The following is a description of a gene set: species: Homo sapiens MAPK family signaling cascades Human Gene Set: REACTOME_MAPK_FAMILY_SIGNALING_CASCADES, and this is the list of marker genes: PAK3, SPTA1, PPP2CA, DUSP16, MAPK1, GFRA1, PSMB7, IL2RG, FYN, FGF9, TYK2, IL2, FGF22, PRKCQ, PSMA4, RASA2, FGF18, FGF2, PPP2R5A, RASA4, FGFR2, KIT, CCND3, PSMC3, MAPKAPK5, PEBP1, KALRN, PSMC2, RASGRP4, PRKACA, RALGDS, RASAL2, FGF10, PSMA1, CSK, FLT3, PPP2R5B, PSMB2, AGO3, FRS2, EGFR, FGFR3, MYC, FGF17 (fibroblast growth factor 17), TEK, EPGN, PDGFB, DUSP4, PSMA5, TNRC6A, PAK1, PSMB1, FGB, GRB2, CDC42EP3, PPP2R5C, HRAS, SHC3, IL17RD, BTC, NRG1, PSMA7, FNTA, PIK3R1, RET, PDE6D, NRG4, IL6R, FNTB (farnesyltransferase, CAAX box, subunit beta), PRKACB, RAG1, FGA, MAPK12, FGG, TNRC6B, IGF2BP1, JUN, PAQR3, PSMD11, LAMTOR3, MIR34B, GRIN2B, FOXO3, CDC42, DLG1 (discs large MAGUK scaffold protein 1), RASAL1, PDGFA, RASGRF2 (Ras protein specific guanine nucleotide releasing factor 2), SPRED3, BRAP, NEFL, FLT3LG, SOS1, PSPN, FGFR4, IRS1, ABHD17C, PSMA2, MAP2K1, PPP1CB, JAK1, EREG, RASAL3, PSMD1 (NCBI Gene Id 5707), PRKG2, CAMK2G, PSMD12, PPP1CC, NF1, IQGAP1, RGL1, JAK2, DUSP1, FGF1, PSMB4, DLG4, RASGRP1, APBB1IP, IL3, CNKSR1, PPP5C, NRAS, DUSP7, PSMC6, USP17L2, RAP1A, CAMK2D, JAK3, HSPB1, ARRB2, RAG2, MMP2, ARAF, GRIN2D, SPTAN1, RCE1, MRAS, PSMD2, CDC42EP5, GDNF, DUSP2, TNRC6C, TLN1, UBB, FGF8, SHC1, UBA52, HGF, PSMD14, PPP2R5D, CDC14A, PTPN11, FGF6, PSMC5, PTPN3, ICMT, DNAJB1, CALM1, AGO4, MAPK6 (NCBI Gene Id 5597), MOV10, SPTBN1, KBTBD7, LRRC7, PSMC4, FGF5, MMP10, LAT, NRTN, PSMC1, ZDHHC9, PSMD6, ARL2, KLB, IL6ST, NCAM1, FGF19, EGF, RANBP9, IL5, ACTN2, FGF23, SPTBN5, SEPTIN7, RASA3, RASGRF1, PDGFRB, GOLGA7, BRAF, IL5RA, RASA1, CSF2, MARK3, SPTBN2, PHB1, MET, IL2RA, SHC2, AREG, SPRED2, PPP2R5E (NCBI Gene Id 63385), MAP2K2, SRC, FOXO1, RGL3, ITGA2B, DUSP5, KSR1, PIK3CA, MAPK3, WDR83, PTPN7, IRS2, RASGEF1A, PSMD7, ARTN, PPP2CB (NCBI Gene Id 5516), CDK1, KL, LAMTOR2, DAB2IP (DAB2 interacting protein), PSMA6 (proteasome 20S subunit alpha 6), PSMD13, PPP2R1B, SHOC2, GRIN1, PEA15, ETV4, YWHAB, VWF, FGFR1, DLG2, BCL2L1, GFRA3, MIR34C, FGF4, CDC42EP2, FGF7, RAC1, FN1 (fibronectin 1), KRAS, MAP3K11, NCOA3, FGF20, RAPGEF2, PIK3CB, ERBB4, RBX1, PSMB6, PRKACG, ERBB3, DUSP6, NRG2, ABHD17B, CNKSR2, SPTBN4, KSR2, LYPLA1, SPRED1, ERBB2, VCL, GFRA4, ACTB (actin beta), DUSP8 (dual specificity phosphatase 8), CAMK2B, MAPK4, DUSP10, CSF2RB, PDGFRA, XPO1, HBEGF, FGF16, SEM1 (NCBI Gene Id 7979), PSMD3, CUL3, ABHD17A, UBC, ADRM1, ITGB3, IL2RB, PSMD8, SPTB, CSF2RA, ACTG1, PSMA3, AGO1, ARRB1, NRG3, AGO2, FRS3, DUSP9, PAK2, IL6, PIK3R2, PSMB5, DLG3, RAP1B, GFRA2, SYNGAP1, CAMK2A, PTPRA, RAF1, RPS27A, PPP2R1A, FGF3, ANGPT1 (NCBI Gene Id 284), TGFA, PSMB3, CDC14B, RGL2, RASGRP3, IL3RA, KITLG, PTK2